Given this list of marker genes Cenpu, Ube2d1 (ubiquitin-conjugating enzyme E2D 1), Vrk2, Mad1l1, Psma5, Ankle2, Cenpt, Cenpn, Ubb, B9d2, Psmc5, Cenpa, Seh1l, Ppp2r5a (protein phosphatase 2, regulatory subunit B', alpha), Ppp2r5b, Zwilch, Cc2d1b, Emd, Lbr, Tubb4b, Ube2c, Kif2b, Tuba8, Psma1, Psmb4, Psmd13, Tubb2b, Nup205, Aurkb, Chmp2b (charged multivesicular body protein 2B), Ppp2r1b, Kntc1, Ist1, Psmd7, Tuba1c, Smc3, Nde1, Tuba3b, Anapc2, Vrk1, Lmnb1, Psmc2, Tubal3, Ccnb1, Nup133, Clasp1, Cenpm, Anapc10, Ska1, Tubb6, Mad2l1, Rps27a, Xpo1, Psmd12, Anapc7, Sumo1, Itgb3bp, Psmc3, Nup85, Nudc, Ndc1, Kpnb1, Psmd1, Anapc15, Nup155, Psma7, Psmd6 (proteasome (prosome, macropain) 26S subunit, non-ATPase, 6), Psma6, Cenpq, Psmc4, Ran, Psma3, Ppp2r5d, Ube2s, Psmc6, Cenps, Lmna, Psma4, Spc24, Cenpe, Psmb7 (NCBI Gene Id 19177), Ndel1, Tuba1b, Rad21 (RAD21 cohesin complex component), Kif2c, Psmc1, Tubb4a, Psmb5, Chmp2a, Ppp2r2a, Cdk1, Tuba4a, Psmb6 (NCBI Gene Id 19175), Stag1, Plk1, Cdc26, Psma2, Tuba1a, Dync1li2, Mis12, Nup93, Ndc80, Dynll1, Ube2e1, Cdc23, Hdac8, here is a description of the gene set: Reactome Pathway: Mitotic Metaphase and Anaphase This event has been computationally inferred from an event that has been demonstrated in another species.<p>The inference is based on the homology mapping from PANTHER. Briefly, reactions for which all involved PhysicalEntities (in input, output and catalyst) have a mapped orthologue/paralogue (for complexes at least 75% of components must have a mapping) are inferred to the other species. part of: M Phase studied in species Mus musculus electronically inferred by orthology from the curated human pathway